The following is a description of a gene set: The regulated release of corticosterone into the circulatory system. Corticosterone is a 21-carbon steroid hormone of the corticosteroid type produced in the cortex of the adrenal glands. species: Mus musculus Mouse Gene Set: GOBP_CORTICOSTERONE_SECRETION, and this is the list of marker genes: Nrg1, Tspo, Crhr1, Kcnq1, Crh, Tac1, Pomc, Ecrg4, Selenom